The following is a description of a gene set: Human Gene Set: REACTOME_POST_TRANSLATIONAL_PROTEIN_MODIFICATION Post-translational protein modification studied in species Homo sapiens, and this is the list of marker genes: GOLGB1, B4GALT3, CCNF, PSMA3, B4GALT2, USP47, WDR48, DCAF10, TUBB6, TMED7, XPNPEP2, TRAF3, KTN1, JOSD1, PEX13, ING2, LARGE1, MATN3, NUP35, MIA3, TUBB2A, NFU1, PSMG3, SMC1A, HSP90B1, RAD23B, PRND, AMELX, JMJD4, BPIFB2, ASB12, APOL1, DAG1, PSME4, AGBL4, POMT2, H2AC21, GALNT8, SUMF1 (sulfatase modifying factor 1), H2AC6 (NCBI Gene Id 8334), MAN1C1, ANKRD9 (NCBI Gene Id 122416), PRKCSH, MCFD2 (multiple coagulation factor deficiency 2, ER cargo receptor complex subunit), GMPPB, THSD7A, TGFA, TUBB4B, CPM, PSMA1, LIAS, SUZ12, USP17L10, KLHL11, CTBP1, USP44, USP25, SEC16B, F9, FUT3, TRAPPC1, SEL1L, LMAN2, TUBB2B, ASGR1, FGA, DAXX, GALNT18, H4C9 (NCBI Gene Id 8294), FN3KRP, STT3A, MGAT5, UBE2J2, GALNT2, MUCL1, OGFOD1, SIAH2, MYC, NUP85, GP2, USP49 (NCBI Gene Id 25862), LYPD1, MGAT2, WDR5, SEC24A, DCTN2, DERL2, PSMB5, IKBKG, ASXL1, LYPD3, NLRP3, RAB9A, RPS27A, DCUN1D3, AGBL1, STAM, CD55, PSMC2, KIN, UGGT2, DPH2, TRAPPC4, ARRB1, LYPD6B, TUBB4A, ARFGAP2, RHOT1, TRIM25, COPS5, SATB2, ASB5, DYNC1LI1, RAB43, F7 (NCBI Gene Id 14068), POMP, RPL8, TTL, MUC16, CUL4B, DNMT3B, UBE2F, USP17L22, ASB7, RAE1 (NCBI Gene Id 8480), ALPL, ARCN1, H4C11, AGTPBP1, USP34, FUT8, LY6H, MGAT1, GNE, TMEM129, RAB10, ALG8, TAF10, GALNT4, FOXK1, NUP43, JOSD2, ATXN3L, RAB2B, DYNLL2, FBN1, AURKB, VHL, DPH3, MOGS, PSMD2, LY6G6D, RNF40, DCTN6, TRAF6, PSMB7, NUB1, CHRDL1, ARSH, TTLL7, AREG, MAVS, RAB8A, PIGA, CCDC8, DCAF8, UBE2M, TUBA3E, CALM1, NUP188, TTLL3, ALG12, STAMBPL1, B3GNT3, USP17L29, DPM1, ALPG, TRIM28, H2AC25, RNF2, GORASP1, MBD1, LYPD4, HLA-A, RAB25, UBXN1, SEC22A, TUBB1, IZUMO1R, USP13, STAG2, USP42, H4C6, GPC3, RECK, SMURF2, TGFBR2, DYNC1I1, LMAN2L, FOXO4, SERPIND1, DDA1, FBXO31, PSMA5, IGFBP4, SEC24C, ASB13, TRAPPC5, COPS8, LGALS1, USP11, UBE2B, TOP2A, GPLD1, RPS23, DDX17 (NCBI Gene Id 10521), USP16 (NCBI Gene Id 10600), KLHL9, CSF1, ANK2 (ankyrin 2), ASB17, RABGGTA, FBXO27, SLC35A1, ACTR5, USP5, BMP15, TNFAIP3, EID3, TIMP1, MBD5 (NCBI Gene Id 55777), HIF1A, MUC12, RAB40C, CDC25A, MGAT3, H2AC12, SENP1, DOLK, MUC6, RAB18 (NCBI Gene Id 22931), RNF146, COPZ2, PPP6C, RAB36 (NCBI Gene Id 9609), MUL1, RNF7, PSMB9, LY6E, PIGB, DCAF13, NUP37, H4C1, P4HB, TTLL6, PSMF1, AMDHD2, SUDS3, RCE1, CCDC22, NR3C1 (NCBI Gene Id 389335), DCAF11, UBXN7, RIPK1, PIGT, TUBA4B, EIF2AK2, RAB21, KDELR2, H2BC4, EEF1AKMT2, FEM1C, HIPK2, MGAT4B, METTL22, TUBA8, MCRS1, DNMT1, USP33 (NCBI Gene Id 23032), PENK, PSME2, PEX12, USP37, UBE2H, APP, YY1, PIGN, TECTB, VDAC3, CAPZA3, INO80, PIGF, B4GALT6, UFD1, PML, RAB22A, SOCS3 (suppressor of cytokine signaling 3), TP53, CHGB, FDX1, ARF5, H2BC9, USP10, FOLR1, CNIH3 (cornichon family AMPA receptor auxiliary protein 3), RELA, NSMCE3, GALNT11, H2AC19, COPG1 (NCBI Gene Id 51137), USP20, DDX5, LSAMP, SPTBN4, NUP98 (NCBI Gene Id 51457), TTLL11, KLHL20, PDIA3, SMAD2, H2BC8, ASB16, TADA3, KLHL2, RUVBL1, PIGH, CTR9, ADAMTS2, ESR1, PSMG2, RNF181, UBA2, PSMB6, COMMD1, ARSI (arylsulfatase family member I), DHPS, NAPB, MUC13, OTUD7B, TGFB1, USP19, UBE2E3, GATA3, RPN1, USP17L26, FCGR3B, USP21, AMFR, CTSC, SUMO2, KDM8, SSPOP, TMED9, HRC, NEU2, MANEA (NCBI Gene Id 79694), RAB44, GAS6, TECTA, METTL21A, MARCHF6, PHC3, NUP54, TPR, EEF1A1, NUP42, GCNT1, ART3, ALG14, HLTF, POMGNT1, RNF168, NR5A1, H4C16, NUDT14, SOCS2, SEH1L (NCBI Gene Id 81929), USP17L20, SPSB1, PTRH2, RAB42, GALNT7, ACTR10, RAB31, FBXW5, EMID1, DRG1 (developmentally regulated GTP binding protein 1), ITIH2, BTBD6, ARF3, FBXL8, VASH2, RBBP5, RAD18, DOLPP1, TPST1, TTLL10 (tubulin tyrosine ligase like 10), ARSB, DMP1, CDC20, NR1H3, FBXO22, ST8SIA4, TTLL2, DCTN5 (NCBI Gene Id 84516), B3GNT4, F8, RAB41, OBSL1, AMER1 (NCBI Gene Id 160176), VDAC2, XRCC4, PIGZ, AGBL2, SLC17A5, USP17L3, CFP, DDB1, LYPD2 (LY6/PLAUR domain containing 2), UBA52, PROZ, SMAD1, USP17L18, COL7A1, WAC, THSD4, COG4, DDOST, PSMD8, GAN, FBXO7, RIPK2, GCNT3, UBE2Q2, GNPNAT1, ASB11, RAD23A, PSMB1, COG7, BIRC3, ANO8, SPP1, CNTN3, SEC13, CHST10, USP17L28, ARSK, UBE2S, H2BC18, RNF5, FURIN, B3GALNT2, USP8, SATB1, DCAF4, ST3GAL1, MEN1, KBTBD8, ARF4, KLHL21, H2BC21, COPS3, USP17L5, FBXL18, TNKS2, ZC3H15, HK1, TRAPPC9, NUP50, GLB1, SEMA5B, LIPT2, PSMB2, AMBN, HDAC4, UAP1, CREBBP, SMC5, USP17L2, TNIP1, NUP153, GALNT16, SOCS5, RAB3A, TTLL13, TRIM13, H4C3, HDAC7, OTULIN, FBXW2, NOD2, DHRSX, H4C2, SQSTM1, ULBP2, MBD6, TBC1D20, ASB3, PSMD10, ZNF350, CDCA8, DYNLL1, NFE2L2, SYVN1 (NCBI Gene Id 84447), C1GALT1, SMC3, DPM3, PEX5, RAB39B, NEU1, B3GNT6 (NCBI Gene Id 192134), SLC35C1, STT3B, VNN2 (vanin 2), CNTN4, ARSF, GBF1, NCOA2, RAB11B, GCNT7, ERCC8, THRA, GALNT10, FUT10, B3GNTL1, PSMA2, SIN3A, USP17L27, RAD21, MGAT4C, SEMA5A, APOA5, FBXL12, NFKBIA, ALG11, UBA6, NEGR1, CUL9, DDB2, FN1, THY1, SPARCL1, FBXO32, TTLL5, APOA1, PNPLA2, FSTL1, USP15, ACTB, HDAC2, UBE2I, SCG3, ETF1, FBXO44, ARRB2, POMK, RPA1, EEF2, FBXW10, PPARA, FBXW4, ARSL, H2BC15, IFIH1, TMED2, RAB8B, COG5, EP300, WRN, ST6GALNAC6, ALPI, USP14, SHISA5, CGA, GALNT15, H4C13, RAB6A, IGFBP5, TRAPPC3 (NCBI Gene Id 27095), GFPT1, PLAUR, RBBP7, CNIH2, OSTC, NSMCE4A, GALNTL6, RANGAP1, NR1I2, LY6K (NCBI Gene Id 54742), LYPD5, ARSD, RENBP, INCENP, ALG1, WSB2, UCHL5, NR3C2, ELOB, TUSC3 (NCBI Gene Id 7991, tumor suppressor candidate 3), PREB, ST3GAL6, ANK3, RBX1, RNF139, OGT, PIGX, FUOM, ST3GAL4, SPON1, CP, SAFB, BECN1, MGAT4A, YOD1, RAD52, RAB26, A4GNT, MSLN, LMAN1, VCP, ASGR2, COMMD7, H4C14, RCN1, PIAS3, COMMD9, UHRF2, XPC, DCUN1D5, PHC2, RNF123, RCCD1, USP48 (NCBI Gene Id 84845), ANK1, ARF1, BTRC, RAB40A, UBD, RAB4A, GOLM1, FBXO40, H4C8, LAMC1, FBXL20, ZRANB1, ADAMTSL5, LY6G6C, PSMD3, KCTD6, DBT, USP17L4, PLET1, USP17L11, H2AC14, HERC2, BET1L, STX17, MAN1A1, TTLL12, USP17L1, USP17L19, PCGF2, RTF1, CMAS, TTLL4, B3GNT9, ST8SIA1, FBXW7, BABAM1 (BRISC and BRCA1 A complex member 1), PSMD7, FBXO11, KLHL3, ADAMTSL2, ASB18, DNMT3A, LEO1, RAB3B, CUL2, LRRC41, SEC31A, FEM1B, ADAMTS17, RAB3D, ADAMTS19, FAM20C, CAPZB, SRD5A3, DTL, FPGT, TRAPPC2L, UBE2E1, USP18, H2BC1, USP4, GALNT13, MPDU1, TRRAP (NCBI Gene Id 8295), NOTUM, ALG10B, CDH2, TNKS, LMAN1L, DLAT, ADAMTS14, CDK1, USP17L12, SEC24B, FBXL15, SNX3 (sorting nexin 3), MUC3A, SAR1B, MUC1, RAB32, MAN1A2, GGCX (NCBI Gene Id 2677), UBE2D3, ALB, C1GALT1C1, PRSS41 (NCBI Gene Id 360226), PIGG, DPM2, ST6GALNAC1, SEC16A (SEC16 homolog A, endoplasmic reticulum export factor), PSMB8, ART4, OST4, CD52, IGFBP7, NTM, VWA1, CUL3, ASB15, H2AC20, PIGC, AR, RTN4RL1, USP17L17, COPB2, TOPORS (NCBI Gene Id 641432), SHPRH, H2BC26, PGR, SMC6, UBE2R2, PSMG1, NUP160, ALG6, ADAMTS4, PALB2 (NCBI Gene Id 79728), NSMCE1, WDTC1, LAMB1, OPCML, HIF3A, H4C5, TDG, RNF128, CHST8, H4C15, RPL27A, GRIA1, NTNG1, NR4A2, H2BC12, MUC5AC, CBX5, FBXW9, MBTPS1, CSNK1D, TUBB8, TMED10, PIGP, NAPA, RARA, ADRB2, CALR, INO80C, ST8SIA6, TMEM132A, PSMG4, OTUB1, GALNT12, MUC20, RAB24, NEURL2, RAB13, RABGGTB, DPP3, USP17L8, GPAA1 (glycosylphosphatidylinositol anchor attachment 1), RIOX1, PSMD11, FBXL22 (F-box and leucine rich repeat protein 22), H2BC17, RIGI, UIMC1, DERL1, VGF, H2AC17, TAF9B, RNF144A, VASH1, HNRNPC, RAB27A, DNAJC24, CBX8, USP22, VDR (vitamin D receptor), CBX2, ASB8, PSMB3, ABRAXAS1, RNF103, H2AC16, PARP1, KLHL41, EEF1AKMT1, SPTBN5, PROS1, NUP210, CDKN2A (NCBI Gene Id 1029), ST6GAL2, H2BC6, OTUD7A, USP12, AGBL5, CHD3, SCMH1, ACTL6A, BMP4, APC, GOSR2, CALU (calumenin), SENP8, INS, NTNG2, SVBP, TNIP2, RIOX2, AXIN2, THRB, FBXO41, TRAPPC2 (trafficking protein particle complex subunit 2), RNF135, COPS6 (COP9 signalosome subunit 6), PIAS2, SERPINA10, MFGE8, MAGT1, RAB17, PRSS21, PIGO (phosphatidylinositol glycan anchor biosynthesis class O), GALNT5, VCPKMT, COPS7B, RAB5C, TTLL8, YKT6, COMMD5 (NCBI Gene Id 90980), UGGT1, ASB2, SPACA4 (sperm acrosome associated 4), PMM2, KBTBD13, H4C12, IKBKE, OTUD3, RRAGA, MUC15, RAET1G, DCUN1D4, H2BC14, COMMD6, DPAGT1, VCPIP1, CUL4A, NR2C1, FBXO9, ADAMTS6, MAT2B, COMMD3, PCNA, RAB35, USP17L25, GPS1, RING1, NRN1L, FBXO17, DYNC1LI2, KBTBD7, ST3GAL5, NPLOC4, NUP155, ZBTB16, ENAM, PSMD9, ADAMTS10, ADAM10, ARSG, NUP88, RAB30, ETFB, CFTR, PSMA4, USO1, RPS6, FBXL7 (F-box and leucine rich repeat protein 7), BRCC3, H2AC8, USP26, RAB29, PGAP1, LY6D, POLB, RAB14, MMRN2, RAB15 (RAB15, member RAS oncogene family), NOP58, COMMD4, PSMD13, TPST2, B3GLCT, FBXL19, VDAC1, LHB, TUBA1B, EDEM2, MDM2, CBX4 (chromobox 4), TFG, WSB1, TRAPPC6B, NEU4, COPA, BTBD1, RAB39A, FBXL3, SEC24D, PUM2, AAAS, SUMF2, LIPT1, DYNC1I2 (NCBI Gene Id 1781), B3GNT8, SKIC8, MAP3K7, USP30, NAGK, LTBP1, NUCB1, TUBB3, GALNTL5, NUP205, PDIA6, KBTBD6, KAT2A, NUP62, PIGV (NCBI Gene Id 55650), CCNA1, H2BC7, B4GALT1, CST3, PIAS4 (protein inhibitor of activated STAT 4), SPRN, PSME1, JMJD6, DPH5, PCSK9, ADAMTS18, EIF5A, DNAJC3, USP28, BET1, FBXL14, DCTN1, TFPT, SUMO1, COPS4, CAPZA1, RAB1A, NUP58, ADAMTS8 (NCBI Gene Id 11095), RWDD3, ZNF131, TMEM258, UBE2D2, FEM1A, C3 (complement component 3), NDUFAB1, ASB6, ADAMTS1, NRIP1, TNC, COMMD10, POFUT2, ASB9, PEX2, CEACAM5, USP17L24, POM121, EEF2KMT (NCBI Gene Id 196483), NPM1, UBA1, RAB2A, FAM20A, PSMA7, BLM, FBXL4, DCTN4, BIRC2 (NCBI Gene Id 329), H2BC13, SELENOS, INO80E, ARFGAP3, IDE, H2BC3, CNIH1, RAB40B, FBXO21, MAN1B1, ADAMTS5, MVD (mevalonate diphosphate decarboxylase), OTOA, ASB1, SPSB3, THSD7B, MAN2A1 (NCBI Gene Id 4124), TRIM27, H2AC15, EDEM1, ASB10 (ankyrin repeat and SOCS box containing 10), POMGNT2, AXIN1, B4GAT1 (NCBI Gene Id 11041), KDELR3, UBE2V2, OTUB2, SEC23IP, H2AC11, KCTD7, UMOD, SMAD3, COPS2, LARGE2, SPTA1, UBA3, NEDD8, NUP133, PSMB10, SENP5, TAB1, SAE1, NANP, RAB20, RWDD1, HGS (NCBI Gene Id 9146), POM121C, SENP2, PSCA, TPGS2, FUCA2, RNF185 (ring finger protein 185), MUC7, PTEN, DRG2, THSD1, PSMC4, COG3, CUL7 (NCBI Gene Id 9820), PTP4A2, COMMD2, BABAM2 (BRISC and BRCA1 A complex member 2), WDR20, NDC1, NCOA1, DAD1, B3GNT5, TULP4, U2AF2, MUC4, CAND1, SPTBN1 (spectrin beta, non-erythrocytic 1), ACTR1A, H2AC1, PIGS, PSMA6, SPON2, KDELR1, MDM4, ADAMTS15, BARD1, DHDDS, MELTF, PARK7, BCL10 (BCL10 immune signaling adaptor), ST8SIA5, UBE2T, GALNT1, RAB33A, UBE2L3, FBXW8, TRIM4, UBE2G2, SPP2, STC2, FKBP8, ETFBKMT, ST3GAL2 (ST3 beta-galactoside alpha-2,3-sialyltransferase 2), COP1, CETN2, ST8SIA3, NUP214, LYPD8 (NCBI Gene Id 648444), SKP1, APOB, CCP110, PPARG, C4A, RAB6B, PSMC6, DLST, AHSG, PSMD1, MRTFA, FUCA1, TTLL1, SCG2, B3GNT7, MDGA1, SEC31B, SCFD1 (NCBI Gene Id 51681), PIGY, TRAPPC6A, ADAMTS12 (NCBI Gene Id 81792), CISH, FGG, MDC1, BAP1, UCHL3, DYNC1H1, UBE2D1, TUBA1C, LRRC49, FBXO6, CLSPN, CKAP4, PPP6R1, SERPINC1, OS9 (NCBI Gene Id 10956), RAB11A, PSMD6, EDEM3, RAB1B, SDC2, COPE, DPH1, NOD1, PSME3 (proteasome activator subunit 3), RNF152, MXRA8, NAE1, KLHL25, CNTN5, AFP, NSMCE2, RAB5A, UBE2Z, TUBA3D, CDC34, ADAMTS13, PIGK, STX5, RORA (NCBI Gene Id 6095), NPL, ALG3, COMMD8, MUC5B (mucin 5B, oligomeric mucus/gel-forming), TP53BP1, FBXO15, NR5A2, AGBL3, RAB12, PRKN, TGFBR1, UBE2G1, GCNT4, DCUN1D2, L3MBTL2, FBXW11, HIC1, PSMC3, CAMKMT, USP17L21, PIGQ, PSMB11, TTLL9, ST3GAL3, COPG2, AMTN, FBXO30, STAMBP, PIAS1, GOLGA2, PSMC1, H2AC7, MPI, H2BC5, SEC22C, PSMD5, GALNT17, SBSPON, USP17L15, VCAN, GMPPA, SEC23A, FBXO2 (NCBI Gene Id 4930), B4GALT4, SEM1, THBS1, H4C4, PAF1, FN3K, DCAF5, NAPG, PSMD14, RTN4RL2, PIGM, TUBA4A, SP100, TUBA1A, USP17L30, PSMD4 (NCBI Gene Id 5710), RAB23, FBXO10 (NCBI Gene Id 26267), TNIP3, TUBAL3, NUP93, IGFBP3, CASP8AP2, JMJD7, UBB, TF, DCAF17, KNG1, RAB3C, ARSJ, KDM1B, STAG1, UBE2W, NEU3, ABRAXAS2, COPZ1, MEPE, CYLD, LRR1, TRAF2, SPTAN1, TOP2B, FOLR2, VNN1, MLEC, NFRKB, SP3, USP24, TEX101, ALG9, SUMO3, GALNT3, SPTB, FBXO4, H2AC13, RAB38, KLHL5, KAT2B, ICMT, TFAP2A, DOHH, FSTL3, SPTBN2, PPP6R3, CHML, MMRN1, RAET1L, NR1H4, USP9X, ADAMTS20, GFUS, GFPT2, ZBED1, ST6GALNAC2, GCSH, AURKA, FBXW12, SOCS6, HSPA8, BMI1, PPARGC1A, F5, GANAB, ASB14, ST6GALNAC4, CDC73, EIF5A2, COG6, INO80B, CCN1, RAB7A (RAB7A, member RAS oncogene family), FUT11, TRAPPC10, TOMM20, ASB4, RNF20, ST6GALNAC3, MDGA2, COG2, H2AC18, NR1H2, PEX10, CD109, MITF, PRMT3, NGLY1, RAB19, POMT1, GALNT14, LAMB2, TOP1, KLHL22, COPS7A, INO80D, NFKB2, UBC, ADAMTS7 (NCBI Gene Id 374629), F2, PSMD12, CUL1, SMAD7, MUC21, DCAF6, TGOLN2, USP17L13, UBE2A, CANX, ENGASE, ADAMTSL3, OTUD5, PSMB4, KEAP1, PSMA8, SEC22B, GPIHBP1, APLP2, ALG5, BST1, WFS1, PHC1, PRSS23, APOA2, FBXL13, NICN1, TADA2B (transcriptional adaptor 2B), CHM, CEACAM7 (CEA cell adhesion molecule 7), BIRC5, HCFC1, RHOA, GALNT6, ACTR8, CTSA, NRN1, PIGL, PSMC5, FBXL5, SMAD4, B4GALT5, THBS2, RAB37, PIGW, ADAMTS3, ASPH, RFT1, BGLAP, MTA1, STS, ADRM1, DCUN1D1 (NCBI Gene Id 54165), PRKDC, USP7, PIGU, TOMM70, HNRNPK, CD59, LMO7, APOE, FOXL2, ATXN3, RAB5B, ALG10, KLHL13, FBXL16, MUC17, RAB33B, H2BC11, MAN2A2, TUBA3C, ARFGAP1, USP3, MYSM1, UBE2K, UCHL1, RAB34, NANS, TMED3, FCSK, ASXL2, TFAP2C, ARSA, TPGS1, RXRA, CUL5, IL33, PGM3, STAM2, RPN2, FGF23, EVA1A, PMM1, NSF, NUP107, ALG13, DCAF16, MIA2, RAB27B, CDKN1A, NCOR2, ADAMTSL4, DPH6, PEX14, B4GALNT2, ST6GALNAC5, COG1, BRCA1, UBE2C, PAAF1, IGFBP1, SERPINA1, SPSB4 (splA/ryanodine receptor domain and SOCS box containing 4), H2AC4, ADAMTS16, DCTN3, H2BC10, CTSZ, F10, UBE2N, GMDS, ELOC, DCAF7, TMEM115, PROC, KLHL42, RAB9B, ATXN7, EPAS1, ADAMTS9, USP2, RANBP2, ALG2, B3GNT2, COPB1, RPS2, CCNA2, IL6, TFAP2B, DPH7, CHST4, COG8, ANKRD28 (NCBI Gene Id 23243), GOSR1, ST8SIA2 (NCBI Gene Id 8128), CAPZA2, ADAMTSL1 (ADAMTS like 1), FOXK2, TUBB8B, GALNT9, NUS1, ST6GAL1, HDAC1, SPSB2, SKP2, RAB7B, RAB4B, QSOX1